Given this list of marker genes DNAI2, SCGB1A1, DRC3, IQCG, DNAAF1, CHD9NB, FABP6, here is a description of the gene set: species: Homo sapiens Human Gene Set: NAKAMURA_BRONCHIAL_AND_BRONCHIOLAR_EPITHELIA from publication Nakamura N, Kobayashi K, Nakamoto M, Kohno T, Sasaki H, Matsuno Y, Yokota J (PMID 16491115) To identify tumor markers and differentiation markers for lung adenocarcinoma (AdC), we analysed expression profiles of genes against three cases of type II alveolar epithelial cells, bronchiolar epithelial cells, and bronchial epithelial cells, respectively, and 10 cases of AdC cells isolated by laser capture microdissection. Hierarchical clustering analysis indicated that AdC cells and noncancerous lung epithelial cells are significantly different in their expression profiles, and that different sets of differentiation markers are expressed among alveolar, bronchiolar and bronchial epithelial cells. Nine genes were identified as being highly expressed in AdC cells, but not expressed in noncancerous lung epithelial cells. Sixteen genes were identified as differentiation markers for lung epithelial cells. Real-time RT-PCR analysis of 45 lung AdC cases further revealed that expression of four tumor markers in AdC cells was significantly higher than that in noncancerous lung cells and that expression of ten differentiation markers was retained in a considerable fraction of lung AdC cases. Five tumor markers and seven differentiation markers were not expressed in peripheral blood cells. Similarities and differences in expression profiles between normal epithelial cells from different lung respiratory compartments and AdC cells demonstrated in this study will be informative for the molecular diagnosis of lung AdC. Differentiation markers for normal bronchiolar and bronchial epithelial cells.